The following is a description of a gene set: This event has been computationally inferred from an event that has been demonstrated in another species.<p>The inference is based on the homology mapping from PANTHER. Briefly, reactions for which all involved PhysicalEntities (in input, output and catalyst) have a mapped orthologue/paralogue (for complexes at least 75% of components must have a mapping) are inferred to the other species. species: Mus musculus Reactome Pathway: Immunoregulatory interactions between a Lymphoid and a non-Lymphoid cell part of: Adaptive Immune System electronically inferred by orthology from the curated human pathway, and this is the list of marker genes: C3, Cd300e, H2-M3, Hcst, Slamf7, Trem2, Pianp, Cd3e, Col17a1, Cd300ld3, Igll1, Siglecf, H2-M9, Siglece, Klrb1a, Icam2, Cd3d, Cd40lg, Cd300ld4, Clec4g, Ifitm1, B2m, Klrk1, Raet1e, Siglec1, H2-M10.6, Trem1, Cd300ld (NCBI Gene Id 217305), Cd96, Ifitm3, Cd8b1, Ifitm2, Cd226, Crtam, Cd81, H2-Q10, H2-Q7, Pilra (NCBI Gene Id 231805), Itgal (NCBI Gene Id 16408), Ulbp1, Siglecg, Nectin2 (nectin cell adhesion molecule 2), Itgb7, Icam4, Jaml, Cd19 (NCBI Gene Id 12478), Icam5, Treml2, Cd200r2, H2-M2, H2-M10.2, Itgb2, Itga4, Cd300lb, Cd300ld5, Treml1, Cd3g, H2-M10.1